The following is a description of a gene set: Human Gene Set: chr13q32 species: Homo sapiens, and this is the list of marker genes: RN7SL164P, CALM2P4, RPL15P18, UBAC2-AS1, RNU6-83P, CLYBL-AS1, BRD7P5, MTND5P2, MTND6P18 (MT-ND6 pseudogene 18), ASNSP3, CLDN10, NUS1P4, GGACT, FARP1, LINC00554, RPS6P23, DCT, SOX21, MIR3170, NALCN-AS1, RNY4P27, CCR12P, RN7SKP9, ZIC2, ARF4P3, RPL21P112, IPO5, HMGB3P4, UGGT2, CLDN10-AS1, RN7SKP8, RNA5SP36, DOCK9-DT, PCCA-AS1, DZIP1 (DAZ interacting zinc finger protein 1), MEMO1P5, CLYBL, CFL1P8, COX5BP6, ZIC5, DNAJC3-DT, LINC00557, STK24, DOCK9, GPR18, RNF113B, RN7SL585P, LINC01039, RAP2A, MTCYBP3, RN7SL60P, RNA5SP37, FTLP8, LINC00391, HS6ST3, FARP1-AS1, RNU6-62P, H2AZP3, MIR623, RPL7L1P12, AMMECR1LP1, PCCA-DT, CLYBL-AS2, HSP90AB6P, GAPDHP22, LINC00411, SOX21-AS1, TMTC4, LINC00456, LINC00359, CYCSP35, MIR4306, MIR4501, HMGN1P24, NDUFA12P1, RNY3P8, TM9SF2, TGDS, PSMA6P4, ABCC4, UBAC2, RPS26P47, RPL7AP61, OXGR1, DNAJC3 (NCBI Gene Id 5611), GPR180, TULP3P1, RN7SKP7, SLC15A1 (NCBI Gene Id 6564), LNCARGI (lncRNA antiviral response interferon signaling inducer), PCCA, DOCK9-AS1, MBNL2, STK24-AS1, GPR183, LINC01232